Given this list of marker genes CTBP1, ME1, PXDN, HOXB2, IRF4, WDCP, MAP3K8, ABCC5, HAUS2, IDE, CADM1, TSEN54, LYSET, NCOA3, MAN2A1, NRIP1, TENT4B, ZNF236 (NCBI Gene Id 7776), API5, HIF3A, NDST3, STARD7, FAM53B, ATP10D, RBM20, TRAK2 (trafficking kinesin protein 2), HNF4G, IL1RAP, TRNP1, FAM118B, MPV17L, IL6R, TXLNG, CHFR, PAQR8, APPBP2, ANGPTL2, CAMSAP2, KHNYN, ZDHHC23, ADAMTS14, BLMH, FADS6, THRB, HDX, RBM41, NFATC2IP, PUS10, MICOS10, TLN2, GMCL1, TMEM219, SLC25A43, KIF21A, ACSL6 (acyl-CoA synthetase long chain family member 6), BEND4, SLC17A5, IGDCC3, EML1 (EMAP like 1), ANO3, HAPLN4, BLTP3A, SEC14L2, STAC2, TRIM9, CDCA7L, CAMTA1, ZFHX3, NAA15, ARPP19, BLZF1, LGR4, UNC5D, IRS1, KY, KCND1, RTN4RL1, TNKS (tankyrase), CEP68, MEIOC, ACTL6A, ZNF516, ZSWIM5, ZFHX4 (zinc finger homeobox 4), PXN, CEP164, CCSER2, ZNF281, CLEC16A, CYB5R4, CCDC117, BDP1, PPP1R12B, APH1A, TOMM40L, IFRD2, STK11IP, SOX30, SLC11A2, AXL, LOXL4, DDHD1, EML4, WASHC4, ADAM19, PBX2, CEP350, NUDT5 (NCBI Gene Id 11164), CPEB2, MTERF1, NHSL3, HPGD, HTR7, CPNE5, ZIC3, SECISBP2L (SECIS binding protein 2 like), MYT1, CAND2, LATS2, PTK2, ZNF629, MORC2, KCNN3, RAB3D, PLXDC2, FAM169BP, FBN1, SLC35G1, CBX1, MIA2, UBR3, USP31, ATG2B, ABRACL, YARS1, SH3GL2, USP33, TPD52L2 (TPD52 like 2), CPLX1, HOMER1, ANKRD13A, PTGS1, RBBP5, ARMC1, PITPNC1, BBC3, TFDP2, DGKE (NCBI Gene Id 8526), IMPA2, PCTP, ATP8A1, CHIC1, DNAJC27, RNF4, CTBP2, GATA6, HNF1B, ADAM10, ATP11C, CEP85, LPAR2, CPT1A, RSBN1, PXDNL, TMEM263, DHX35, ELMOD2, PCDH15, ADCY1, FREM1, MOGS, UNC80, CTAGE15, AJUBA, PLXNA2, SIAH3, IL16, TNRC6C, NRN1, IKZF2, WDR43, FNTB, NKD1, PPM1E, GSKIP, CACUL1, RASSF5, COL21A1, TCERG1, NATD1, HTT, RAB39B, GIGYF2, DPP4, ZNF646, MEOX2, MYCBP2, IRX2, TBCEL, PRDM15, PIP5K1A, FAM107B, GLCCI1, GLT8D1, DOCK11, MTUS1, KCNS3, LYN, LAD1, BMP2, HDAC7, CDC25A, CIAO2A, NRP1, PLRG1, APPL1, MAP3K1, TMEM41B, IRF2, TMEM121, CRELD1, ZNF264, TNPO1, STK10, ZNF609 (zinc finger protein 609), CTAGE6, CHD1, IPMK, JOSD1, CEP170B, HCK, KLHL6, PLPPR5, GALNTL6, LIN28A, PPP4R3A, SNX7, ERBB3, TRIL, H2AZ1, ALDH18A1, UBE2R2, ZFYVE28, AP4E1, HCCS, CDC42SE1, BACH2, RPS6KL1, COL24A1, SLC14A1, TXNL4A, CREB1, CUL1, SOX12, DCP2, POLR3G, EPB41L4A, ITGAL, ZRANB1, FEN1, SCML2, MBTD1, ENDOV, TMEM245, PDE3B, DMXL1, here is a description of the gene set: Genes predicted to be targets of miRBase v22 microRNA hsa-miR-4324 in miRDB v6.0 with MirTarget v4 prediction scores > 80 (high confidence targets). studied in species Homo sapiens from publication Chen Y, Wang X (PMID 31504780) Human Gene Set: MIR4324